Given this list of marker genes PHB1, ITGAV, VSIG4, C4A (NCBI Gene Id 720), CFHR3, CALR, CR1, C1QBP, CFHR5, PTX3, CFHR2, CRP, MASP2 (MBL associated serine protease 2), APCS, MEGF10, CFHR1, CD93, CFHR4, CFH, ITGAM, ITGB2, here is a description of the gene set: Binding to an opsonin, such as a complement component or antibody, deposited on the surface of a bacteria, virus, immune complex, or other particulate material. Human Gene Set: GOMF_OPSONIN_BINDING species: Homo sapiens